Given this list of marker genes Nsg1, Zfyve16, Marchf1, Cmtm6, Mapkap1, Ehd4, Litaf, Abca7, Plpp2, Cftr, Epha8, Clvs1, Tpcn1, Dnajc13, Mr1 (major histocompatibility complex, class I-related), Eps15, Mmgt2, Pmepa1, Sorcs2, Slc15a4 (NCBI Gene Id 101014), H2-M11, Mon2, Atp13a3, Slc39a14 (NCBI Gene Id 213053), Stam, Tmem63a, H2-Q7 (NCBI Gene Id 15018), Mtmr2, Ephb1, Rbsn, Bok, Stam2, Snx6, Wdr81, Rab14, Sphk1, Pml, Marchf8, Epha4, Tmem30a, Clip3, Rcc2, Neu3, Gga1, Vamp3, Cln3, Snx1, Tmem9b, H2-M10.6, Eea1, Dagla, H2-M2, Steap4, Arl8b, Snx4, Slc30a10, Zfyve9, Ntrk2, Ubxn6, Slc1a1, Atp7a, Snx16, Snx30, Mtmr4, Snx12, H2-Q1, Washc1, Kif16b, H2-D1, Kir3dl2, Slc9a9, Clcn4, Vamp8, Lamp5, Anxa1, Snx5, Pla2g4e, Osbpl6, Itch, Appl1, H2-M5, Gga3, Hsd17b6, Slc35d3, Ldlrad4, Inpp4a, Stx7, Tmem184a, Tmem63b, Rab21, Slc5a7, Hgs, Nsg2, Snx7, Kir3dl1, Stx12, Slc11a2, Slc9a3, Or51e2, Washc5, Snx3, Snx2, H2-M10.1 (histocompatibility 2, M region locus 10.1), Vti1b, Atp11b, Fgd2, Rnft1, Arf6, Ifitm2, Egfr, Tom1, Entrep1, Vps16, Wls, Rab5c, Rep15, Gpnmb, Hps6, Vps41, Abcb6, Rufy1, Sh3gl1, Marchf3, Syndig1, Fcmr, Gripap1, Psen1, Clvs2, Pi4k2b, Wdr91, Ifitm7, Snx13, Gria1, Rab5b, Dtx3l (NCBI Gene Id 209200), Rab4b, Rab11fip5, Atp11c (ATPase, class VI, type 11C), Ntrk1, Inpp5b, Dop1b, Llgl1, Lamp3, Ocrl, Snx20, Mcoln3, H2-K1, Pla2g4b, Rac1, Rab5a, Washc3, Mmgt1, Atp9a (ATPase, class II, type 9A), Ifitm3, Rab4a, Arc, H2-Q2, H2-M10.2, Tmem163, H2-Q10, D130043K22Rik, Pi4k2a, Pld3, Ehd1, Appl2, Pikfyve, Clcn3, Snx8, Sorl1, Vps13b, Pdlim4, Vps33b, Snx21, Plekhf2, Tsg101, Washc4, Slc9a6, Sh3gl3, Washc2, Zfyve28, Cd274, Tlr9, Snx27, Zmpste24, Atp13a4, Slc31a1, Gga2, H2-T22 (histocompatibility 2, T region locus 22), H2-M10.4, Napepld, H2-Q6, Kcnh1, here is a description of the gene set: studied in species Mus musculus Mouse Gene Set: GOCC_EARLY_ENDOSOME_MEMBRANE The lipid bilayer surrounding an early endosome.